Given this list of marker genes PYGL, AK8, PRKAG2, APRT, ACSS1, PRKAG1, MPPED2, ACSS2, PRKAG3, CFAP45, FBP1, here is a description of the gene set: Human Gene Set: GOMF_AMP_BINDING species: Homo sapiens Binding to AMP, adenosine monophosphate.